Given this list of marker genes ERG, ZNF43, CDX1 (NCBI Gene Id 1044), IRX5, ALX1, GTF2I, NFATC4 (NCBI Gene Id 4776), CDKN2B, TGIF1, BCL3, GTF2B, BORCS8-MEF2B, ETV6, ZNF211, TLE1, PAX2, ZNF136, ADRA1B, SNAPC1, ELAVL2, MCM3, PTGER4, EZH2, CUL4A, SIM1, CHAF1B, SMARCD2, RGR, ING2, CRK, FPR1, CDKN2A, MYBL2 (NCBI Gene Id 4605), ETV3, ZBTB18, AR (NCBI Gene Id 367), GPSM2, CCL3, FOXM1, SOX5, RFX2, ADNP2, TRIP4, BRD1, HSF2, POU3F1, SIX6, TBRG4, KDM5C (lysine demethylase 5C), ESR2, IRF2, ADORA1, ZNF124, ETS1, CREG1, JUN, CCL17, IRF1, RARA, GRM1, ARL3, FOXE1, PTGER2, MEF2A, LRRFIP1, MEF2D, FOS, TFAP2A, LHX2, CXCR2, NFKB2, ZNF254, FPR3, ZNF267, SOX9, APLNR, ELL, HIVEP1, ZEB2, ID4, HMGA2, CBFA2T2, CXCL2, ZNF516, PAX6, PAX5, ETV1, DLX5 (distal-less homeobox 5), MYC, GNA13, NFKB1, RUNX3, GRPR, PHOX2B (NCBI Gene Id 8929), CDKN1A, PTGFR, POU3F4, FZD2, SMARCA5, GAS7, POU2F1, SOX4, ZNF143, TAF5, BCL6 (NCBI Gene Id 604), ADRA1A, HNF1A, PRRX2, HMGB2, ILF3, TSC22D1 (TSC22 domain family member 1), NFYA, EWSR1, ZNF345, KLF7, MAFG, ARNT, GTF2H1, CHD4, ZBTB24, GLI1, TULP3, ELOA, NSD2, CDKN3, TSC22D2, GNAT2, MNDA, GNAI2 (NCBI Gene Id 2771), ZFHX3, CXCR6, MYCN, LANCL1, APLP2, FOXN3, MECP2, NR3C1, ATF3, HOXB1, ZNF141, HDAC2, OLIG2, CBX4, FOXD1, ZNF324, NPY2R, REL, HCAR3, BATF, PROP1 (NCBI Gene Id 5626), TAF7, OVOL1, TAF4, GTF2F2, C5AR1, DNMT1, PAWR, EIF2AK2, TLE3, RRH, P2RY14, STAT1, GNA12, ADRB1, KMT2A, SP4, PIK3CG, TOX4, JUNB, EP300, PRH2, NRF1 (NCBI Gene Id 4899), GPR182, FOSL2, FOXG1, ERCC6, SCAND1, RORA, KLF11, FOSL1, STAT2, ELF3, CITED2, JUND, ADCYAP1R1 (NCBI Gene Id 117), ZFX, ZBTB43, SSX1, CHRM3, EN2, MS4A2 (NCBI Gene Id 3477), CXCL8, MEOX1, SP100, HLTF, CHD2, ZNF177, ETS2, PPARA, E2F3, MYCL, HNF4G, MXD1, ZNF195, EGR1, TBX4, RLF, EGR4, CXCL1, ZNF264, CXCL9, TLX1, DPF1, AIF1, PTH2R, BDKRB1, EGR2, PER1, NR4A2, SATB1, SMAD1, GPR171, ZBTB48, PPARG, MEN1, TBX1, CXCR4, ERCC8, ZNF217, FZD9, NPAS1, MSX1, ATF2, STAT6, KLF6, JADE3, ADRB2, ELF4, INSM1, KDM5A (lysine demethylase 5A), BRCA1, KDM4A, ZNF646, RCAN1, GPR183, MYOD1, ZNF157, here is a description of the gene set: Human Gene Set: MODULE_123 Genes in the cancer module 123. studied in species Homo sapiens